Given this list of marker genes HCN4, JUP, MYL2, MYL3, GYG1 (NCBI Gene Id 2992), PRKAG2, here is a description of the gene set: An inversion of the T-wave (which is normally positive). species: Homo sapiens T-wave inversion Human Gene Set: HP_T_WAVE_INVERSION